The following is a description of a gene set: species: Homo sapiens Human Gene Set: chr7q36, and this is the list of marker genes: RN7SKP280, ENSG00000199370, RPS27AP12, PRKAG2-AS2, SHH, ATP6V0E2, RN7SL569P, RPL21P76, REPIN1, ATP6V0E2-AS1, ZNF775, GIMAP3P, ASB10, ENSG00000298692, CDK5, GIMAP8, ZNF775-AS1, BLACE, ZNF467, GHET1, XRCC2, DPP6, HTR5A-AS1, MNX1, RBM33, INSIG1-DT, ZNF425, CNPY1, ZNF786, HTR5A, ZBED10P, RNU7-20P, FABP5P3, YBX1P4, IQCA1L, PAXIP1, GALNT11, SEPTIN7P6, RNY3, CHPF2, H2BK1, C7orf33, LINC03010, GIMAP4, LINC01287, TMUB1, TMEM176A, NOS3, RN7SL72P, LINC00689, PAXIP1-AS2, ENSG00000228151, ZNF282, ZNF777, ZNF767P, UBE3C, PRKAG2, SMARCD3, GIMAP6, ENSG00000284691, LINC00244, ZNF783, PAXBP1P1, RN7SL521P, RN7SL76P, ETF1P2, ENSG00000222012, ENSG00000212590, ABCF2-H2BK1, BET1P1, NOM1, ENSG00000306674, THAP5P1, GIMAP7, LRRC61, ZNF398, ABCB8, AGAP3, ALDH7A1P3, ACTR3B, CCT8L1P, ATP5PBP3, ENSG00000287636, EZH2, MIR153-2, RPL32P17, NCAPG2, KMT2C, ASIC3, INSIG1, ENSG00000290007, GIMAP1-GIMAP5, EN2, RNY1, MIR595, SLC4A2, MNX1-AS2, ABCF2, LINC01022, ENSG00000296818, ENSG00000294258, PAXIP1-DT, ACTR3C, ENSG00000234210, FASTK, TMEM176B, RNU6-604P, LINC01003, REPIN1-AS1, NPM1P12, AOC1, RNU4-31P, PTPRN2, VIPR2, ENSG00000288051, RPL36AP28, MIR3907, PTPRN2-AS1, EN2-DT, COX6B1P1, ZNF862, RPL36AP30, MIR671, RNU6-650P, DYNC2I1, RNF32-DT, RN7SL845P, CUL1, RARRES2, PIP5K1P2, KCNH2, RNF32-AS1, TRPC6P3, ENSG00000289588, NUB1, DNAJB6, RNF32, PDIA4, RHEB, ENSG00000223872, MNX1-AS1, ZNF746, SSPOP, KRBA1, PRKAG2-AS1, GIMAP1, ATG9B, WDR86-AS1, GIMAP5, ENSG00000288608, LINC00996, ESYT2, WDR86, RNY4, GALNTL5, LMBR1, GBX1, STRADBP1, ZNF212, CRYGN, RBM33-DT, MIR5707, GIMAP2